Given this list of marker genes STK11, SIX4, PTBP1, PRKAA1, CTDSP1, STRADB, here is a description of the gene set: species: Homo sapiens Human Gene Set: WP_MIR124_PREDICTED_INTERACTIONS_WITH_CELL_CYCLE_AND_DIFFERENTIATION mir-124 predicted interactions with cell cycle and differentiation